The following is a description of a gene set: part of: Synthesis of substrates in N-glycan biosythesis electronically inferred by orthology from the curated human pathway studied in species Mus musculus This event has been computationally inferred from an event that has been demonstrated in another species.<p>The inference is based on the homology mapping from PANTHER. Briefly, reactions for which all involved PhysicalEntities (in input, output and catalyst) have a mapped orthologue/paralogue (for complexes at least 75% of components must have a mapping) are inferred to the other species. Reactome Pathway: Synthesis of dolichyl-phosphate-glucose, and this is the list of marker genes: Nudt14